Given this list of marker genes Tnfsf13b, Ada, H2-DMa, Tnfsf13, Tnfrsf13c, here is a description of the gene set: Any process that activates or increases the frequency, rate, or extent of germinal center formation. Mouse Gene Set: GOBP_POSITIVE_REGULATION_OF_GERMINAL_CENTER_FORMATION species: Mus musculus